Given this list of marker genes Ryr3, Ryr2, Ryr1, Bnip1, Pkd2, here is a description of the gene set: Enables transmembrane transfer of calcium ions from an intracellular store to the cytosol on induction by increased calcium concentration. studied in species Mus musculus Mouse Gene Set: GOMF_CALCIUM_INDUCED_CALCIUM_RELEASE_ACTIVITY